The following is a description of a gene set: Binding to a PDZ domain of a protein, a domain found in diverse signaling proteins. Human Gene Set: GOMF_PDZ_DOMAIN_BINDING studied in species Homo sapiens, and this is the list of marker genes: GNG5, ATP2B4, FZD2, MAP2K2, SDC2, LNX2, EXOC4, KCNJ4, NLGN1, CXADR, ARHGEF16, F11R, SNTA1, GRIK2, FZD3, GNG12, SLC9A3, LNX1, SLC22A4, CLCN3, NHERF1, GRID2, CIT, ADAM17, NKD1, PLEKHA1, LPAR2, RAPGEF2, SNTG2, CXXC4, CCDC88C, SLC26A6, ERC1, PDZK1, HCN2, CACNG3, GRIA1, NSF, CADM1, FZD4, LIN7C, ATP2B2, CLDN16, TBC1D10A, SLC34A1, LPAR1, CRIM1, LLGL2, ACVR2A, FZD1 (frizzled class receptor 1), KIDINS220, BAIAP2, SSTR2 (NCBI Gene Id 6752), SLC22A12, GRM7, MPP3, GPR37, TMEM88, FZD8 (frizzled class receptor 8), CFTR, TGFBR3, SRR, PTEN, FZD7, DTNA, PRKN, ARHGAP29, USHBP1 (USH1 protein network component harmonin binding protein 1), ADRB1, MUC17 (NCBI Gene Id 402576), PLEKHA2, ADGRB1, DLG4, PSEN1, SHISA6, KIF14, TAMALIN, ABTB3, CRIPT, SHISA9, SNTB1, SLC22A5, DOCK4, ACOX1